Given this list of marker genes MARCHF8, ENG, PRKAB1, MAN2B1, PDLIM4, NINJ1 (NCBI Gene Id 4814), LOXL1, ATF3, FEZ1, GADD45A, FHL2, ABCA3, EXT2, DMPK, DGKA, CDKN1A, APOC1, PCNA, TAX1BP3, ZP3 (NCBI Gene Id 7785), SURF1, NDN (necdin, MAGE family member), HRAS, NHLH2, SCGB2A2, SCRIB, PLIN2, SMAD7, CARTPT, DCAF7, DDB2, GALE, SMTN, ZNF7, TMSB15A, H2AC6, PMAIP1, FAS, SUSD6 (sushi domain containing 6), BAK1, NEFL, APLP1, GDF15, VIPR1, CES2, PLK3, BCL6, TST, BTG2, IGFBP6, ACTA2, LSR, SLC3A2, LCAT, VCAN, QSOX1, BBC3, CTDSP2, SPAG1, here is a description of the gene set: The transcriptional program regulated by the tumor suppressor p53 was analysed using oligonucleotide microarrays. A human lung cancer cell line that expresses the temperature sensitive murine p53 was utilized to quantitate mRNA levels of various genes at different time points after shifting the temperature to 32 degrees C. Inhibition of protein synthesis by cycloheximide (CHX) was used to distinguish between primary and secondary target genes regulated by p53. In the absence of CHX, 259 and genes were up or down-regulated respectively; only 38 and 24 of these genes were up and down-regulated by p53 also in the presence of CHX and are considered primary targets in this cell line. Cluster analysis of these data using the super paramagnetic clustering (SPC) algorithm demonstrate that the primary genes can be distinguished as a single cluster among a large pool of p53 regulated genes. This procedure identified additional genes that co-cluster with the primary targets and can also be classified as such genes. In addition to cell cycle (e.g. p21, TGF-beta, Cyclin E) and apoptosis (e.g. Fas, Bak, IAP) related genes, the primary targets of p53 include genes involved in many aspects of cell function, including cell adhesion (e.g. Thymosin, Smoothelin), signaling (e.g. H-Ras, Diacylglycerol kinase), transcription (e.g. ATF3, LISCH7), neuronal growth (e.g. Ninjurin, NSCL2) and DNA repair (e.g. BTG2, DDB2). The results suggest that p53 activates concerted opposing signals and exerts its effect through a diverse network of transcriptional changes that collectively alter the cell phenotype in response to stress. from publication Kannan K, Amariglio N, Rechavi G, Jakob-Hirsch J, Kela I, Kaminski N, Getz G, Domany E, Givol D (PMID 11402317) Human Gene Set: KANNAN_TP53_TARGETS_UP Primary up-regulated targets of TP53 in the H1299 (lung cancer) cell line. species: Homo sapiens